Given this list of marker genes PAX5, RUNX1 (RUNX family transcription factor 1), ELF2, CBFB, ELF1, BLK, here is a description of the gene set: studied in species Homo sapiens RUNX1 regulates transcription of genes involved in BCR signaling Human Gene Set: REACTOME_RUNX1_REGULATES_TRANSCRIPTION_OF_GENES_INVOLVED_IN_BCR_SIGNALING